Given this list of marker genes ZMYM2, AKAP12, ADGRL2, TTC23, EOMES, RBBP6, ENC1, GGNBP2, SYT4, MITF, ZNF506, SERINC5, ZNF676, RALYL, MAP4K4, TXLNG, ANKHD1, ZNF287, CRLF3, DENND1B, TRHDE, TJP1, FYB1, CHSY3, MICU3 (NCBI Gene Id 286097), RAB39B, HOXB5, SFT2D1, UBN2, ATP11C, BLCAP, AGPAT4, MT2A, CBLN1, PLCXD3, CIPC, GLP2R, ZNF420, RCN1, SMIM9, PTGER4, RNF38, PTPRB, GAS2L3, MRC1, CPSF4, PAX9, DOK6 (NCBI Gene Id 220164), ANKRD50, PRELID2, ZNF765, ORMDL1, GJA1, C6orf62, PDIA6, CAMSAP2, ZNF117, TGIF1, ZNF30, INTU, PRRG1, RTF1, INPP5A, ARHGAP20, ATRN, SLC38A1, WNK3, NEK7, TBC1D12, ANKMY2, CPEB2, CRISPLD1, DTNA, TMEM170A, ZNF493, COL4A1, HS3ST3A1, FAM234B, NEFL, ZNF730, QSER1, CCM2, KLHL7, SOX6, ZNF461 (zinc finger protein 461), PDE4B, NSRP1, SEC24A, TOX3, HMGB2, ZBTB34, MARCKS, CNKSR2, ZNF195, NDUFA5, TMEM135, FBXO32, CLEC1A, CLCN3, RNF150, JCAD, GAP43, RBM25 (NCBI Gene Id 58517), CSE1L, FBN2, RBM47, PDE7A, PPIF, LPP, LAMP1, MAB21L2, KCNK5, ABHD18, SPSB4, TOP1, PLAAT5, ABRAXAS2, PKP4, TENT5A, PCMT1, OSBPL8, SPOCK1, EPHB2, RORA, NDUFA2, SIPA1L1, TBR1, HS6ST2, CALCRL (NCBI Gene Id 10203), ZNF138, FASTKD3, NIN, PNMA2, NKX2-1, ZCCHC2, TNRC6A, MAP4, LPGAT1, SLC1A1, RBPMS2, CGGBP1, CAMTA1, HYCC2, NRK (Nik related kinase), PRDM10, RAI14, BICD2, IL6R, CNOT6L, RPP30, BRWD1, MIS18A, NAA50, DNAJC6, MTSS1, KLF3, ROBO2, LONRF3, GRK5, BLTP1, ARL8B, STX12, NUFIP2, MTCL1, ZNF721, AGAP1, KMT5A, TMEM131L, GPRC5B, APAF1 (apoptotic peptidase activating factor 1), LPAR1, POU4F2, STON2, LIPH, MTHFS, ARNT2, XIAP (NCBI Gene Id 8257), ATG12, DIPK2A, NOL4, CNTLN, TRPM7, CBLL1, CASP7, SEC14L1, FZD3, RPL31, SESN2 (sestrin 2), SOCS6, MEIS1, CHST7, SRPK1, MET, LMBR1, CASP10, MED4, BBX, GTDC1, ETNK1, PIK3R3, POU2F1, BTBD8 (BTB domain containing 8), PRTG, PDPK1, ADGRG2, VTI1B, TRIM14, POM121C, NPY5R, THAP12, TOX, MEX3C, SLC7A1, TRIB1, PPP4R4, WBP4, RGS8, TMEM263, ZNF559, FBXO25, RPRD2, ISCA2, SCG5 (secretogranin V), GLCE, PKIA, NUAK2, MAP3K20, DCUN1D1, LYPLA1, IPPK, NAA16, LHFPL2, MAP3K5 (NCBI Gene Id 4217), RRAS2, CDK17, IPO5 (NCBI Gene Id 3843), CCDC158, ZNF189, PRR14L (NCBI Gene Id 84194), TGFBR2, B4GAT1, PPM1K, ANKRD33B, ESRP1, WEE1, TMEM33, ELOVL2, IGSF8, ZBTB43, LGR4, CA2, MTF1, C3orf52, GSK3B, SESN3, ADAM23, ZNF716, MIA2, SLC16A6, STARD3NL, CCNT2, MYCT1, SAFB, CLDN12, ATXN7L3B, TCP11L1, SNRPG, CAPRIN1, IL12B, SNX5, ASF1A, ZEB1, NCOA6, RXFP1, GPR22, RCOR1, MAPRE1, ZNF257, EPAS1, NAP1L3, TMOD1, IPMK, ASAH2B, PIP4K2B, TXNRD1 (thioredoxin reductase 1), FRMD5, C2orf69, GABRG1, PKDCC, TNRC6C, HDAC7, NFIA, ADNP, MYH2, MCFD2, DCBLD2 (discoidin, CUB and LCCL domain containing 2), ANXA10, ZDBF2, TTC7B, PPP1R12A, ATXN1, TMED5, NLK, SMS, SENP6, KDM5A, SPHKAP, SEMA4B, CEP350, MIGA1, UBE2K (ubiquitin conjugating enzyme E2 K), BACH2, AP1S2, ZC3H12C, ENTPD5, NSD2, RAP2B, GLS, SATB2, TBC1D15, CARD8, SH3BGR, GXYLT1 (glucoside xylosyltransferase 1, NCBI Gene Id 338841), LIN54, JARID2 (NCBI Gene Id 3720), ATP11B, CNOT4, ATXN7, MINDY2, FZD5, MED12L, KLHL28, ZNF469, PAK2, ELOVL3, TCF24, DDX47, NLGN4Y, SEC23A, ESRRG, STAT5B, NEK6, SLC12A2, FMR1, ZBTB18, COL11A2 (NCBI Gene Id 494120), STT3B, ZBTB2, SV2B, AHCTF1, CXCL12, ODF2, NLGN4X, NACC2, HNF4G, SLC4A7 (NCBI Gene Id 9497), GET1-SH3BGR, HDX, TNKS2, CCDC186, TMEM38B, TUSC2, SSH2, MEF2A, ZNF395, ZNF839, MAGOHB, CREBZF, G3BP2, PRDM1, LRAT, FOSB, IFIT5, EPSTI1, CCSAP, WDR37, CBFA2T3, MDFIC, HAS2, CDH1, TYMSOS, CCL7, NRXN1, SYNJ1 (NCBI Gene Id 8867), CCNH, AUTS2, PARD6B, NUP50, PTEN, ATP6V1E1, TRIM63, CELF2, RAP1A, NUS1, NCOA1, TAB3, RAB11FIP2, BNIP3L, WHAMM, CEMIP2, ZNF90, PRPH2, DOCK3, HEXIM1, TNPO1, ELF2, TMEM245 (NCBI Gene Id 23731), CNN2, RUFY2, MARCKSL1, ACSL6, SPOPL, VKORC1L1, FGF2, ZNF267, PNRC2, CDS2, PPP2R5E, SEC23IP, SLC4A4, ZIC5, HTR2A (5-hydroxytryptamine receptor 2A), ZBTB44, AKAP11, UBE2R2, ZNF468, FREM1, FUT4, ELF4, UHMK1, PCDH18, CUL3, CALCR, RAB8B, JMJD1C, LRIG1, COL4A5, ECHDC1, MYH1, BORA, PITPNC1, INTS6, PTPN4, STRN4, ZNF793, PLEKHH2, FUT9, DHX15, RETREG3, GNG2, N4BP1, ADCY1, STK4, VEPH1, ZNF737, MAK16, ZIC4, BEX5, NDFIP2, NIPSNAP2, ZNF626, ZNF99, ANO4, MBTD1, ERBIN, CHUK, C12orf76, SLC6A14, GIMAP7, USP53, STRN, WBP2, RFX3, FGD4, NR6A1, UBE2O, AUH, CAB39, VGLL3, PRKCE, CACUL1, CCNG1, AMBRA1, SDHD, NGLY1, PLAU, FRAT2 (FRAT regulator of WNT signaling pathway 2), UQCRFS1, MCM4, NTS (NCBI Gene Id 96646), SIX4, IGSF10, CBFA2T2, KPNA4, CEP63, BTAF1, RNF168, TRIL, TMPO, TNRC6B, ZNF652, RAD21, MAP7, TSNAX, VCPKMT, PCDH19, NUAK1, PAK6, NAP1L5, VCAN (versican), PNRC1, RAD51AP1, SCN2A, ERBB4, SATB1, CCDC71L, HOXD10, ASXL3, SERINC1, HSPA12A, NEDD4L, FAS, ROBO1, HOXA1, YOD1, POM121 (NCBI Gene Id 9883), MBOAT7, TOP2B, EGR3, CBLB, CAMK2G, TET3, GPSM1, GRM5, SWT1, ZNF107, TNFAIP3, TMOD2, FOXP2, CNR1, MAP3K1, PALS1, KDM4A, PGRMC2, SHROOM2, MAML2, ZNRF2, GUCY1A2, ZNF680, ALDH1A2, PPP4R3B, EXOC3L4, ZNF655, BNIP2, TEX30, DENND4A, TLK1, NCOA2, ZNF208, REEP1, ZNF292, DPP10, AKR1C2, PLXNC1, TNFAIP6, ZIC1, SSBP2, UBE2D1 (NCBI Gene Id 9335), SOWAHC, SEMA6D, CDC40, REPS2 (RALBP1 associated Eps domain containing 2), COG3, EBF3, TMEM68 (transmembrane protein 68), CTCF, PKNOX1, ST20-MTHFS, SLC38A2, PPARGC1A, B4GALT4, C15orf32, ZFHX4, WNK1, NKAIN2, CSNK1G3, ELAVL4, TTC39B, KDM6A, GNRHR, NRXN3, ADAMTS6, here is a description of the gene set: from publication Chen Y, Wang X (PMID 31504780) studied in species Homo sapiens Genes predicted to be targets of miRBase v22 microRNA hsa-miR-23a-3p, hsa-miR-23b-3p in miRDB v6.0 with MirTarget v4 prediction scores > 80 (high confidence targets). Human Gene Set: MIR23A_3P_MIR23B_3P